Given this list of marker genes BNC2, MAP3K4, AJAP1, SOBP, L3MBTL3, SAMD4A, OSBPL8, PPP2R2A, DYNC1I1, GPCPD1, ICA1, POLR1C, REPS2, KBTBD6, PLEKHA5, SPRY3, ATP2B4, KLRD1, FAM217B (family with sequence similarity 217 member B), BAZ1B, MBNL1, LRP6, ANKMY2, MTMR6, FKBP1A, NRIP2, DNALI1, TRAM1, SMCO4, PKD2, RAB8B, PFN2 (profilin 2), PHF6, ABAT, RALA, RCN2, MTERF2, TOMM70, RHPN2, RFX3, SREK1IP1, GTF2H1, GYPA, ATF2, EPHA4, KCNK2, VDAC1, GCLM, PPP2R5C, ACER2, MAP3K13, CELF2, CCL18, HTR2A, BACH2, ABRAXAS2, SRSF2, IRS1, DCX, FOXN2, REXO5, ZMYM2, AMD1, FLRT3, PTPN4, AP3M1, HCN1, KCNK10, CTDSPL, ZNF770, FUT2, PLCB4, MRC2 (mannose receptor C-type 2), PDCD4, CACNB4, UNC13B, CHD2 (chromodomain helicase DNA binding protein 2), CDK5R1, GPR34, SERP1, GNG5, ROBO2, SLITRK1, ABCB10, MAPK8IP1, MFSD6, ARHGEF18, TAB3, NARS2, RPS6KA3, TCF7L2, KIF2A, REV1, TCF12, ARHGAP21, MEF2C, MAPK4, KCNMB1, BIRC6, ZNF750, SLITRK3, NUFIP2, SCYL3 (SCY1 like pseudokinase 3), DGKH, PLEKHA3, KCNJ14, MINAR1, MAP7D2, GPAM, TMED7, ARFGAP2, ALAD, RORA, USF3, LHFPL2, SOCS6, PEX19, ITGB1, ATP10B, RABGAP1L, SCN3A (sodium voltage-gated channel alpha subunit 3), STK38L, RBMS1, PCK2, SACS, ATRN, NCAM2, FCHO2, PLPPR2, GOLPH3, TTC7B, KIF13A, ABI2, CCDC121, BNIP3L, TET1, TAOK1 (NCBI Gene Id 80214), TMPO, AZIN1, LCK, ACVR2B, RIMBP2, EMSY, PPP2CB, ANKRD13C (ankyrin repeat domain 13C), PPP2CA, RNF138, DDHD1, NFYC, MACROD2, TMEM184C, TMEM70, SLC35A1, ITGB8, CSMD1, BPNT2, DGCR2, NTRK2, AMIGO2, NPAS3, CALCB, XPOT, CLCN3, IPPK, CTNNA2, ERBIN, NR3C1, DEPDC5, EPHA7, KDM2B, SH3D19, PHLDB2, HAPSTR1, STC1, DMXL1, FRMD6, SLC1A2, ING3, SPATS2, SESN1, GJA3, PSMA5, SEL1L, SMPD3, PDCD6, DIP2A, CFL2 (NCBI Gene Id 1073), KLHL24, ZFPM2, ZDHHC6, NRG1, PTDSS1, RHOBTB1, CEP97, CEP170B, ATP13A3, IDH2, DUSP10, RAB21, XPNPEP3, ZBTB34, PAM, ARPP19, SPC25 (SPC25 component of NDC80 kinetochore complex), B3GNT2, SLAIN1, GARRE1, PSEN2, TRIM27, ENAH, ZNF197, NEFL, KCND2, NCK2, NUDT4, ZFYVE26, CACNA1E, EZR, DAAM1, CDH9, AKAP12, PRKACB, TMEM59, CPM, TMSB4X, BBOF1, ARHGEF37, AGPAT5, DAGLA, OTUD4, MAL2, here is a description of the gene set: studied in species Homo sapiens Genes predicted to be targets of miRBase v22 microRNA hsa-miR-183-5p in miRDB v6.0 with MirTarget v4 prediction scores > 80 (high confidence targets). from publication Chen Y, Wang X (PMID 31504780) Human Gene Set: MIR183_5P